The following is a description of a gene set: Mouse Gene Set: MIR_466E_5P Genes predicted to be targets of miRBase v22 microRNA mmu_miR_466e_5p in miRDB v6.0 with MirTarget v4 prediction scores > 80 (high confidence targets). from publication Chen Y, Wang X (PMID 31504780) species: Mus musculus, and this is the list of marker genes: Triobp, Sowahc, Sh3bgrl2 (NCBI Gene Id 68100), Papss2, Sema3a, Car10 (NCBI Gene Id 72605), Fsd1l, Gimap9, Larp4, Gpm6a, Amotl1, Xrcc3, Tmem47, Syn3, Tc2n, Dusp7, Tesmin, Extl3, Tasp1, Setd3, 2210418O10Rik, Lhfpl6, Rock2, Adal, Cat (NCBI Gene Id 269322), Pafah1b1, Gcnt2, Prlr, Sh3rf3 (NCBI Gene Id 237353), Onecut3, Stox2, Foxp3, Adcy9, Gcnt4, Gm2026, Elovl6, Arhgef9, Ttc9, Fezf1, Fech, Cdcp3, Treml2, Fbxo43, Ano3, Gria3, Kansl1l, Epas1, Pdzrn4, Enpp1 (NCBI Gene Id 97628), Kpna3, Pfkfb2, Gabrb3, Vamp5, Tmem144, Rab11fip1, Atrx, Cd33, Rdh19, Armc1, Gm14325, Sox5, Trmt2b, Kcne2, Tcte1, Oxgr1, Pstpip2, Olr1, Ankrd29, Cps1, Mill1, Prc1, Septin3, Timm21, Zfp971, Musk, Gatc, Pla2r1, Gnb4, Lamp2, Retn, Lck, Acvr2b, Fgf14, Adcyap1, Pou4f2, Cd4, Them7, Klf6, Rspo1, Il1rap, Atrn, Pirt, Bean1, Rab7, Brwd3, Zfp936, Gm14296, Tmem196, Cckar, E2f8, Enpp2, Hexim1, Nlgn3, Zfp931, Vegfa, Slc6a19, Map10, P4ha3, Il18r1, P2rx7 (purinergic receptor P2X, ligand-gated ion channel, 7), Pou3f4, Sh2d2a, Zfp1009, Fam169b, Zfp516, Trpc6, Iglon5, Pitpnb, Slco2a1, Tshz1, Inhbb, Irag1, Crkl, Nr3c1, Fam180a, Gpr82, Cipc, Stard8, Insyn2a, Phf20l1, Mmp20, Ccpg1, Rgs17, Cplx2, Ap1ar, Fmn2, Pcsk2, Chst11, Trim12c, Arpp21, Ssbp4, Napb, Rslcan18, Elfn1, Nox4, Zfp91, Abraxas1, Enpp6, Gxylt1, Elovl5, Camta1, Acot3, Nxpe3, D630023F18Rik, P2ry13, Septin10, Kpna1, Lnx2, Tcp1, Zfp46, Scai, Rbms3, Eda2r, Vps33b, Ttc39a, Slco3a1, Tead1, Zfand3, Adgra1, Itga4, Zfyve16, Rab9b, Nfat5, Rsph4a